Given this list of marker genes IGSF21, TMEM176B, MS4A7, MRC1, CSF1R, PDGFC, TGFBI, GGTA1, RNASE1, SERPING1, HNMT, GATM, C1QC, F13A1, MS4A4A, GPX3, MAFB, PLTP, STAB1, LGMN, PPIC, CPM, GFRA2, HSPA7, C1QA, CTSL, CD93, CXCL2, CCL13 (NCBI Gene Id 6357), FCGR2B, ATF3, SLCO2B1, CD83 (NCBI Gene Id 9308), ARHGAP18, CCL2, MSR1, PDK4, LMNA, MAMDC2, FOLR2, C1QB, CXCL16, WLS, MS4A6A, VSIG4, DAB2, here is a description of the gene set: Human Gene Set: TRAVAGLINI_LUNG_IGSF21_DENDRITIC_CELL studied in species Homo sapiens from publication Travaglini KJ, Nabhan AN, Penland L, Sinha R, Gillich A, Sit RV, Chang S, Conley SD, Mori Y, Seita J, Berry GJ, Shrager JB, Metzger RJ, Kuo CS, Neff N, Weissman IL, Quake SR, Krasnow MA (PMID 33208946)